Given this list of marker genes TWIST1, ARID1B, TBX5, MAP3K20, KCNH1, CANT1, ROR2, FIG4, EOGT, NOG, ZMPSTE24, RIPK4, FGFR3, HS2ST1, ARSL, PTHLH, GPC4, FGFR1, MED25, RETREG1, LMNA, PIGF, KCNN3, HOXD13, TRPV4, VAC14, FGFR2, NR4A2, TBR1, here is a description of the gene set: Human Gene Set: HP_ABNORMALITY_OF_THE_DISTAL_PHALANGES_OF_THE_TOES studied in species Homo sapiens Abnormality of the distal phalanges of the toes